Given this list of marker genes AAMDC, HS6ST3, TMED8, ACTR6, HAGHL, INPP5K, PSMD2, ENTPD1-AS1, SLC30A8, PURA, PRPF38A, RIPPLY1, PSPH, SRXN1, BTG3, SWT1, AOPEP, GGTLC2, NTHL1, SLC37A3, HSPA1A, MTMR11, GPR155, HLX, VCF1, CLCA4, ZNF646, CFAP20, SLC36A1, HLA-DRA, RASGEF1B, IL34, OR10H1, ILKAP, ZBTB11, NEPRO, FOXP2, SIL1, ZMAT4, PGBD2, EXOC1, GOLGA5, ABCD3, TNFSF15, ASCL3, MYO10, PMCH, KRT23, UBQLNL, GSTCD, SIPA1L2, EHD2, TIFAB (TIFA inhibitor), ASPA (NCBI Gene Id 443), C6orf120, ODF4, CDK5RAP3, RPF1, AHSP, ODAD4, POP5, CHCHD7, H2BC13, IDE, CFAP126, SLFN13, ABCA7, TRIM31, MALT1, CLIC3, PLCB3, BATF, PRDM16, PANK2, KPLCE, KIAA1328, KRT31, LPCAT2, PSMC5, TMEM158, PRKCZ, COPS6, DRC12, SPSB2, ENSG00000235143, TREM2, PYDC1, DPY19L1, RXFP3, LGALS3, DUSP7, SERP1, DOK1, STMN3, ATP6V0B, NAA38, GNA14, SYPL1, ZNHIT1, PARPBP, CLCC1 (NCBI Gene Id 641433), STK3, SEMA5A (NCBI Gene Id 9037), TEKT5, ABHD3, INE1, CFAP276, HSBP1, ZNF280A, ANKRD33, TLX1, LINC00862, SLC30A2, CUTA, KRT18, BHLHE40, DYRK3, PGA3, CAMK1D, PAH, AP3S2, REEP4, DSTN (NCBI Gene Id 11034), PCDHGB7, HSD17B4, ERCC6L (ERCC excision repair 6 like, spindle assembly checkpoint helicase), PGC, ADAM30, FAM170B, AHSA1, RAB1A, SS18L2, GRASLND, TMEM106C, ALDOA, SYMPK, ENSG00000286546, MYL6, FAM20C, MANF, TNFRSF14, PTGES3, ASNSD1, RPL23, AIM2, CZIB, P2RY12, KNSTRN, ING1, ARPC2, RBMS3, TMPRSS4, SSR3, BANK1, IGIP, B3GNTL1, GRAP2, TMEM156, CDH5, LANCL1, OXT, UNKL, MORN1, ICOSLG, GUSB, STX8, IQCC, SPG7, KCNG2, NPFF, CCND1, JPT1, AAMP, FAM3D, HM13, RMND1, TMEM204, LINC00293, HDHD2, TRMT12, C1orf35, TANGO2, PLOD1, C18orf15, CCDC187, LTBR, MAGEH1, NMUR2, WWTR1, MAGEA11, GPR55, SAXO1 (stabilizer of axonemal microtubules 1), ILF2, WDR31, here is a description of the gene set: from publication Baram D, Dekel O, Mekori YA, Sagi-Eisenberg R (PMID 20190146) Human Gene Set: GSE19888_ADENOSINE_A3R_ACT_VS_TCELL_MEMBRANES_ACT_AND_A3R_INH_PRETREAT_IN_MAST_CELL_UP Genes up-regulated in HMC-1 (mast leukemia) cells: Cl-IB-MECA versus incubated with the peptide ALL1 followed by stimulation with T cell membranes. studied in species Homo sapiens We demonstrate that the G protein Gi3 is the cellular target of the adenosine A3 receptor (A3R). By using a cell permeable peptide comprising the C-terminal end of Gαi3 fused to an importation sequence (ALL1) as a selective inhibitor of Gi3 signaling, we show that by coupling to Gi3, the A3R stimulates multiple signaling pathways in human mast cells, leading to upregulation of cytokines, chemokines and growth factors.Following contact with activated T cell membranes, endogenous adenosine binds to and activates the A3R, resulting in Gi3-mediated signaling. Specifically, the majority of ERK1/2 signaling initiated by contact with activated T cell membranes, is mediated by Gi3, giving rise to ALL1-inhibitable cellular responses. These results unveil the physiological GPCR that couples to Gi3 and establish the important role played by this G-protein in inflammatory conditions that involve adenosine-activated mast cells. We used microarrays to detail the effect of ALL1 on gene expression of HMC-1 cells activated directly by the A3 receptor, or by contact with activated T cell membranes.